Given this list of marker genes CYP3A5, UGT1A1, ABCC1, CES2, UGT1A9, ABCC2, ABCG2, CES1, CYP3A4, BCHE, UGT1A10, SLCO1B1, here is a description of the gene set: Irinotecan pathway studied in species Homo sapiens Human Gene Set: WP_IRINOTECAN_PATHWAY